The following is a description of a gene set: Human Gene Set: GOBP_NON_MOTILE_CILIUM_ASSEMBLY The aggregation, arrangement and bonding together of a set of components to form a non-motile cilium. species: Homo sapiens, and this is the list of marker genes: SEPTIN7, CC2D2B, SEPTIN9, GORAB, INTU, GFY, IFT172, DCTN1, IFT122, TMEM80 (NCBI Gene Id 283232), HAP1 (huntingtin associated protein 1), TBC1D32, CENPJ, BBS7, WRAP73, BBS1, CLCN4, IFT140, CC2D2A, RP1, CSNK1D, ATMIN, CCDC13, VANGL2, POC1A (POC1 centriolar protein A), MAK, CEP89, IFT80, IFT74, EXOC5, CEP135, ARL13B, PIBF1, CEP126, MKS1, IFT52 (intraflagellar transport 52), BBS4, CEP250, TTC8, RPGRIP1L, DISC1, IFT88, MKKS, C2CD3, KCNF1, TMEM107, ENKD1, TMEM216, TMEM17, FUZ, KCNQ1, CEP290, MAP4, BBS2, RPGRIP1, CEP131, TOGARAM1, ARL13A, TTBK2, DYNC2H1, CEP350, NPHP3, KCNJ10, PCM1, IFT57 (intraflagellar transport 57), BBS10, MAPRE1